Given this list of marker genes USP46, FSHR, ATXN3, EXOC4, RREB1, HTR1E, FGA, HNF1A, DNAJC22, DAZL, IFNA10, CLCN3, OCM, TMEM26, CALN1, SLC46A3, SUPT3H, NHEJ1, LGI1, PLPPR4, KRT2, DMD, CTSB, CDKL5, DRD1, MAGEA8, ZNF157, SLC15A1, BRD4, TLL1, AKAP3, CAMTA1, CCR3, LECT2, ST8SIA1, KCNA5, KLRC4, NPAS2, HCRTR2, SLC17A1, CMKLR2, POLR1HASP, ITGBL1, RORB, RAD51D, SRPK3, SIX6, MAGEA9, CRHR1, RNF24, COL19A1, IFNA1, PAX6, HOXC11, PTPRR, LDB3, GRIK1, PHOX2B, TBXT, PART1, MAP2K7, MINDY2, KRT34, FZD5, IL7, CDH8, STAC, APOBEC1, GPR19, SPRR2C, JADE3, PTPN20, SLC17A3, ZNF132, ADAMTSL3, OR2B6, ABCB1, EDIL3, ATF2, NR3C2, PSG1, RYR3, IFNA14, NPFF, HSD3B2, CADM4, COL8A1, ADAM20, GCM1, IFNA2, CDC73, NEB, MAP2, GNG4, TENM4, DBT, GLRA3, SERPINA4, ZSCAN26, MDM2, MPP3, TTTY1, here is a description of the gene set: Neighborhood of PTPRR species: Homo sapiens Human Gene Set: MORF_PTPRR Neighborhood of PTPRR protein tyrosine phosphatase, receptor type, R in the MORF expression compendium